Given this list of marker genes Il4, Dusp10, Nfat5 (nuclear factor of activated T cells 5), Igf1, Il1rl2, Brd7, Carmil2, Fbxo38, Efnb3 (NCBI Gene Id 13643), Chst2, Cd1d1, Il1b, Lck, Pdcd1lg2, Stat5b, Tnfsf4, Xbp1, Ambra1, Tgfbr2, Prkaa1, Nfkbiz, Cd1d2, Cyld, Abl2, Has2, Rasgrp1, Chst4, Pik3r6, Ifng, Ywhag (tyrosine 3-monooxygenase/tryptophan 5-monooxygenase activation protein, gamma polypeptide), Vcam1, Nlrp3, Tespa1, Socs1, Cd209e, H2-DMb2, Sox13, Il36b, Zmiz1, Cd83, Shb, Mdk, Tgfb1, Nfkbid, Btn2a2, Bmi1, Flot2, Sirpa, Icosl, Elane, Brd4, Xcl1, H2-Oa, Vtcn1, St3gal4, Ptafr, Fut4, Itga4, Il7r, Pnp, Ptprc, Il12rb1, Runx3, Il6st, Cd44, Cd24a, Bad, Hspd1, Cd40lg, Itgal, Slc4a1, Pycard, Epo, Abl1, H2-Eb2, Thy1, Cd160, Ccl5, Spn, B2m, Ada, Efnb1, Sox4, Card11, Cd59b, Skap1, Coro1a, Smarca2 (NCBI Gene Id 67155), Ptpn22, Pawr, Opa1, Icos, Ihh, Hmgb1, H2-DMb1, Fcho1, Lgals1 (lectin, galactose binding, soluble 1), Slc7a1, Cd55b, Smarcd2, Shh, Cbfb, Actl6a, Gata3, Arid2, Ap3d1, H2-Ab1, Igfbp2, Bcl10, Pck1, Cd47, Rhoh, Zp3, Il12b, Arid1a, Selenok, Ephb4, H2-Ob (NCBI Gene Id 15002), Actl6b, Zfp609, Il21, Ccr2, Jak2, Ager, Klhl22, Il4i1, Gp1ba, Gli3, Il4ra, Irgm1, Dhps, Il15, Prkcz, Vsir, Smarcd1, Socs5, Cd5, Selp, Sash3, Capn1, Sox12, Sart1, Ap3b1 (NCBI Gene Id 97864), Adk (NCBI Gene Id 75969), Il3, Skint1, Egr3, Vav1, Tnfrsf14, Gimap5, Cd46 (CD46 antigen, complement regulatory protein), Ephb6, Cd80, Bcl6, Cd276, Il6, Il23a, Klhl25, Cd209d, Ppp3ca, Nr4a3, Ripk2, Sele, Lilrb4b, Prkcq, Rag1, Pbrm1, Foxp3, Il18, Adam8, Cyrib, Syk, Lgals9, Lgals8, Malt1, Igf2 (insulin-like growth factor 2), Vnn1, Ep300, Cd27, Nr5a2, Smarcc1, H2-DMa, Cd3e, Wnt10b, Gcnt1, H2-Ea, Spta1 (NCBI Gene Id 98361), Itgb2, Tnfsf14, H2-M3, H2-T23, Smarca4, Brd2, Dnaja3, Ccr7, Cd244a, Tnfrsf13c, Ccl2, Cd74, Blm, Ccl19, Alox5 (NCBI Gene Id 232336), Cd81, Tyk2, Dpp4, Cd55, Actb, Mir326, Fadd, Cd274, Gpam, Itpkb, Cav1, Rhoa, Rara, Lilrb4a, Dock8, Tnfsf9, Il2ra, Nck2 (non-catalytic region of tyrosine kinase adaptor protein 2), Smarcb1, Tnfsf13b, Phf10, Cd28, H2-Aa, Smarce1, Efnb2, Lep, Rasal3, Fut7, Hsph1, Gimap3, Anxa1, Cd86, Nck1, Slamf1, Smarcd3, Cd4, Il7, Zbtb7b, Cd6, Kitl, Il2rg, Foxo3, H2-Eb1, Cd209c, Ets1, Irf1, Btnl2, Jak3, Cd59a, Tfrc, Havcr2, Tnfsf11, Il12a, Ccdc88b (coiled-coil domain containing 88B), Rps3, Traf6, Tnf, Hlx, Icam1, Il1a, Zap70, Il2, Smarcc2 (NCBI Gene Id 68094), Kat5, Hes1, Ccl21a, Rela (v-rel reticuloendotheliosis viral oncogene homolog A (avian)), Aif1, Nkap, Hsp90aa1, Irak1, Zbtb1, Lef1, Stat5a (signal transducer and activator of transcription 5A), Runx1 (NCBI Gene Id 12394), Nckap1l, here is a description of the gene set: species: Mus musculus Any process that activates or increases the frequency, rate or extent of leukocyte cell-cell adhesion. Mouse Gene Set: GOBP_POSITIVE_REGULATION_OF_LEUKOCYTE_CELL_CELL_ADHESION